The following is a description of a gene set: Genes having at least one occurrence of the highly conserved motif M160 CAGNYGKNAAA in the regions spanning 4 kb centered on their transcription starting sites. The motif does not match any known transcription factor binding site. Human Gene Set: CAGNYGKNAAA_UNKNOWN from publication Xie X, Lu J, Kulbokas EJ, Golub TR, Mootha V, Lindblad-Toh K, Lander ES, Kellis M (PMID 15735639) studied in species Homo sapiens Comprehensive identification of all functional elements encoded in the human genome is a fundamental need in biomedical research. Here, we present a comparative analysis of the human, mouse, rat and dog genomes to create a systematic catalogue of common regulatory motifs in promoters and 3' untranslated regions (3' UTRs). The promoter analysis yields 174 candidate motifs, including most previously known transcription-factor binding sites and 105 new motifs. The 3'-UTR analysis yields 106 motifs likely to be involved in post-transcriptional regulation. Nearly one-half are associated with microRNAs (miRNAs), leading to the discovery of many new miRNA genes and their likely target genes. Our results suggest that previous estimates of the number of human miRNA genes were low, and that miRNAs regulate at least 20% of human genes. The overall results provide a systematic view of gene regulation in the human, which will be refined as additional mammalian genomes become available., and this is the list of marker genes: GPBP1, TPI1, GAD2, EDA, ACVR2B, PTCHD4, CLIP1 (CAP-Gly domain containing linker protein 1), GRIK3 (NCBI Gene Id 2899), PITX2, TRAM1, CNTN6 (NCBI Gene Id 27255), GABRB3, PLAC1, HOXB2, AKT2, PRKACA, TET2, ORAI2, UBALD2, TBL1X, GNRH2, PRKD1, POFUT1, PDE4D, FBXL21P, ERGIC1, MYO18A, NNAT, SOD2, CER1, DHX30, BNC2, HECTD2, WDTC1, SOBP, SYTL4, EMILIN3 (elastin microfibril interfacer 3), RHOBTB1, TRIB2, NKX2-2, BMP1 (NCBI Gene Id 649), FAM117A, PLAGL2, AFF3, ATP1A2, CACNA2D2, HIGD1B, HOXA7, TNFRSF19, LIX1, YPEL5, HNRNPD, APPBP2, RORC, SAP30L (SAP30 like), CDH5 (cadherin 5), CLSTN2, ZBTB18, CHMP2B, PLPP7, CBFA2T2, MED27, UBR5, ONECUT2, TGIF1, MEF2D, ETS1, GRK5, SRSF8, EIF4A2 (NCBI Gene Id 63124), MPPED2, RPL13, NR3C1, GFRA1 (GDNF family receptor alpha 1), ALB, PPP1CB, TBL1Y, SYNCRIP